Given this list of marker genes ZNF652, PEG10, ZFR2, SNX7, SLC17A1, RNF41, GGCX, ELL2, TRIM15, LCN2, MGP, ENPEP, LIPT1, SERPINB8, BAG2, MMP1 (NCBI Gene Id 4312), CTSS, TRPC6, PNP, SIN3B, H2BC11, AJAP1, GIP, CD84, ELAVL4, EFNB2, RRAGD, P4HA2, PIAS2, SPRY2, IFNA2, CLUAP1, NTSR1, DCX, PFKFB3, FZD1, ITPR3, CGA, OPCML, PLCH1, BUB1, BRDT, OR2F1, COL8A1, DOCK4, MGAT2, IGKV1D-13, MCL1, DYRK3, DMXL2, MAGEA4, RGS16, INSIG1, S100A7, FAM149A, ABHD5, RGL1, PLPPR4, BCLAF3, INVS, ZFY, TAF1B, ENTPD3, H1-4, LRRTM2, TLE3, AP3S2, OLR1, NRCAM, SPICE1, PRKAB1, PSG1, NET1, ACTC1, SLC19A2, PDZK1, SIRPB1, OSER1, DMP1, NR4A3, MAB21L1, CLDN8, DDIT4, VEGFD, LEPR, ZNF81, TAX1BP3, RASA3, CTSL, DNM2, TESK2, HSD17B2, IL1RL2, TLR3, TBC1D8, CCL23, OLIG2, BST1, C5orf22, CRTAM, NCF2 (neutrophil cytosolic factor 2), ZFP69B, FPR3, FXR1, VCAN, GUCY2C, SERPINI1, KIF11, AKAP6, MAP3K8, MAEA, KLHDC10, MAP7, GYS2, CCR1, KCNS3, NR0B1, ADH1B, KCNA3, LARGE1, TAF13, RNASEH2B, SERPINC1, PDGFRL, LGMN, PACRG, PCBP1, SOX5, CST5, RARB, CD24, IRAK3, RND3, RLN1, SSX2IP, BMPR1A, AHCYL2, KLHDC3, PCSK5, SP4, CYP24A1, MINDY2, CTSB, TMEM47, IL17A, USP20, PCDHB11, POM121L6P, RHOBTB3, ACP3, SPIN2A, MTMR1, ESRRG, DHRS7, PARM1, IFNA14, GALNT3, FOXF2, CD5, PARD6B, KRTAP26-1, SPAG1, CXCL5, CEP112, GTPBP10, MLC1, NR3C1, BLNK, SERPINA6, ELK3, LAMA3, TSPYL2, SERPINB5, MYT1L, TNFRSF1B, CDC23, GTF2IRD2, ZNF134, POU3F2, ALB, PEG3, SERPINB9, HES1, GSTA4, RCBTB2, ADAM18, BMP3, BHLHE40, TRAPPC2B, DLAT, USP6NL, PKN2, CXCL11, SPTAN1, IL2RB, LSR, DIXDC1, BBS4, NR4A1, here is a description of the gene set: studied in species Homo sapiens B cells are indispensable for humoral immunity, as they ultimately give rise to antibody-secreting plasma cells. During T cell-dependent antibody responses, naive B cells form germinal centers (GCs), a distinct histologic structure found in secondary lymphoid organs. Naive B cells become activated upon interaction with T cells and antigen presenting cells, and begin to rapidly proliferate and form the characteristic GC structure. To elucidate the overall effect of LRF loss in the GCB cell transcriptome, gene expression microarray analysis of FACS-sorted GCB cells was performed. LRF Flox/+ mb-1 Cre+ mice were used as a control to normalize the potential effects of Cre recombinase, and four RNA samples for each genotype were used for the analysis. from publication Sakurai N, Maeda M, Lee SU, Ishikawa Y, Li M, Williams JC, Wang L, Su L, Suzuki M, Saito TI, Chiba S, Casola S, Yagita H, Teruya-Feldstein J, Tsuzuki S, Bhatia R, Maeda T (PMID 21646720) Genes up-regulated in germinal center B lymphocytes: wildtype versus ZBTB7A knockout. Human Gene Set: GSE28449_WT_VS_LRF_KO_GERMINAL_CENTER_BCELL_UP